Given this list of marker genes ECT2, CWH43, GTF2F2, SRP9, HOXC6, WDR59, TCEAL1, SPAG1, TLR2, MGST2 (microsomal glutathione S-transferase 2), MTCH2, HMGB2, BUB1, STMN2, PRR34, RUNDC3A, EXTL3, AOC1, NDC80, SLC35F6, XRCC2, NBR1, CRYBA4, CST2, CCDC59, ZNF814, GAD2, GGCT, C11orf68, FBXL14, CRBN, BUB1B, SLC48A1, BICC1, VAV1, HOXB6, DNM2, HCN2, NFASC, IL18, GRK1, SUMO2, EEF1AKMT3, GTF2A1, ELF5, AGGF1, ELOVL5 (NCBI Gene Id 60481), TSPAN14, CENPI, ABHD8, TK1, ALDH5A1, RNF2, KIR2DL4, CEP63, ZNF248, PAPOLA, STEEP1, ZNF302, LRP5, GNB5, LYSET, SNX10, SCGB1D2, GCFC2, PTGDR2, CHRNA3, TFAP2B, CYB5B, PPM1B, FAM174C, TCEAL9, PSMA4, TRPM3, GRB7, PRC1, POLB, BEX4, CHCHD3, OSBPL11, CEP55, FOXRED2, CYRIB, DNASE1L1, IMPACT, ARMT1, TBCA, PIK3R2, C10orf95, EEF1E1, KLHDC10, APOLD1, DCAF6, ABHD4, TMEM14A, CDK1, CRTAP, ANKRD27, SECISBP2, CPA4, WDHD1, CAB39, TCFL5, ZNF281, PUM2, GLT8D1, SPATA6L (NCBI Gene Id 55064), GNB3, TLX2, MPHOSPH9, PPP3CA, COL15A1, CFAP46, TACC2, PLAG1, CPPED1, DEPTOR, NET1, LBR, HIGD1A, DLD, FLAD1, SERTAD3, TBX2, GPHN, UBE2E1, PCNX4, TAF7, ZNF674, SNRPE, CYP39A1 (NCBI Gene Id 51302), PLEKHG3, SLC17A1, CDK8, TMEM39B, CDH7, PRDM9, CA2, PIK3CD, TBC1D22A, TDP1, GLTP, UCHL5, RSPH14, AGPAT2, MEA1, SWAP70, HLA-DPA1, ARHGAP11A, CYP21A2, NSMCE4A, MMADHC, BBS10, CLPX, HAGH, MORF4L1, LEPROTL1, THOC7, RPS23, SLC19A2, IDH1, ARCN1, KCTD5, NRL, C1D, TRAPPC11, RMND1, LAPTM4A, NRBF2, FAM8A1, ATP5ME, TCF21, PSTPIP2, PTER, GGPS1, GALNT10, RARS2, SCP2, LYPD1, TTC4, TRMT1L, IDH3A, RNF115, TBCC, ORC4, SCGB1A1, TRPM8, LAPTM5, IFT56, S100PBP, ZNF76, RPL39, FAM163A, KIF23, PCNP, HSPA1L, TRMT5, DNAL4, MRPL41, here is a description of the gene set: Human Gene Set: GSE22033_WT_VS_PPARG_KO_MEF_DN Genes down-regulated in mouse embryonic fibroblasts (MEF): wildtype versus PPARG knockout. In order to identify the molecular mechanisms of PPARgamma phosphorylation at Set273, we generated cell-lines of PPARgamma KO MEFs expressing wtPPARgamma or S273APPARgamma. In addition, because our data showed that PPARgamma ligand drugs such as rosiglitazone and MRL24 blocked this phopshorylation, we treated cells with these drugs, then prepared RNA samples to look at the gene profiling. from publication Choi JH, Banks AS, Estall JL, Kajimura S, Boström P, Laznik D, Ruas JL, Chalmers MJ, Kamenecka TM, Blüher M, Griffin PR, Spiegelman BM (PMID 20651683) studied in species Homo sapiens